The following is a description of a gene set: Reactome Pathway: EPH-ephrin mediated repulsion of cells species: Mus musculus electronically inferred by orthology from the curated human pathway part of: EPH-Ephrin signaling This event has been computationally inferred from an event that has been demonstrated in another species.<p>The inference is based on the homology mapping from PANTHER. Briefly, reactions for which all involved PhysicalEntities (in input, output and catalyst) have a mapped orthologue/paralogue (for complexes at least 75% of components must have a mapping) are inferred to the other species., and this is the list of marker genes: Efnb1, Epha2, Ephb1, Ephb4, Psenen, Ephb2, Efna5, Efna2, Fyn, Efnb2, Yes1, Psen1, Efna4, Efnb3, Epha7, Ephb3, Mmp2, Ephb6